Given this list of marker genes STAT3, GATA6, PDX1, PAX4, KCNJ11, ZFP57, PIK3R1, ZMPSTE24, PLAAT3, HNF1A, NSMCE2 (NSE2 (MMS21) homolog, SMC5-SMC6 complex SUMO ligase), ABCC8, PTF1A, AKT2, MICU1 (NCBI Gene Id 51415), CNOT1, BLK, NEUROD1, PLAGL1, APPL1, INS, HNF4A (NCBI Gene Id 4339), LEPR, BSCL2, HYMAI, LEP, KLF11, PLIN1, PPARG, INSR, AGPAT2, XRCC4 (NCBI Gene Id 7518), LMNA, ALMS1, EIF2AK3, CEL, CIDEC, GCK, LIPE, here is a description of the gene set: A type of diabetes mellitus related not to lack of insulin but rather to lack of response to insulin on the part of the target tissues of insulin such as muscle, fat, and liver cells. This type of diabetes is typically associated with increases both in blood glucose concentrations as well as in fasting and postprandial serum insulin levels. species: Homo sapiens Insulin-resistant diabetes mellitus Human Gene Set: HP_INSULIN_RESISTANT_DIABETES_MELLITUS